The following is a description of a gene set: Human Gene Set: GSE22432_MULTIPOTENT_VS_COMMON_DC_PROGENITOR_UNTREATED_DN species: Homo sapiens Genes down-regulated in amplified multipotent progenitors versus cultured untreated common dendritic cell progenitors. from publication Felker P, Seré K, Lin Q, Becker C, Hristov M, Hieronymus T, Zenke M (PMID 20881193) Dendritic cells (DCs) in lymphoid tissue comprise conventional DCs (cDCs) and plasmacytoid DCs (pDCs) that develop from common DC progenitors (CDPs). CDPs are Flt3+c-kitintM-CSFR+ and reside in bone marrow. Here we describe a two-step culture system that recapitulates DC development from c-kithiFlt3-/lo multipotent progenitors (MPPs) into CDPs and further into cDC and pDC subsets. MPPs and CDPs are amplified in vitro with Flt3 ligand, stem cell factor, hyper-IL-6 and insulin- like growth factor-1. The four-factor cocktail readily induces self-renewal of MPPs and their progression into CDPs and has no self-renewal activity on CDPs. The amplified CDPs respond to all known DC poietins and generate all lymphoid tissue DCs in vivo and in vitro. Additionally, in vitro CDPs recapitulate the cell surface marker and gene expression profile of in vivo CDPs and possess a DC-primed transcription profile. Transforming growth factor-β1 (TGF-β1) impacts on CDPs and directs their differentiation towards cDCs. Genome-wide gene expression profiling of TGF-β1-induced genes identified transcription factors, such as interferon regulatory factor-4 (IRF-4) and RelB, that are implicated as instructive factors for cDC subset specification. TGF-β1 also induced the transcription factor inhibitor of differentiation/DNA binding 2 (Id2) that suppresses pDC development. Thus, TGF-β1 directs CDP differentiation into cDC by inducing both cDC instructive factors and pDC inhibitory factors., and this is the list of marker genes: IL1R2, EXOC2, DDX51 (DEAD-box helicase 51), SLC19A2, POLR1E, TRIM37, PWP2, ALG8, PIGM, RIPK2, NDUFB4, BZW2, ATXN7L3, SEH1L, SNHG7, RUVBL2, BFAR, CDC16, C5orf15, SNRPB2, ORC2, JAGN1, POLR3G, POP1, INTS15, RCE1, CTSZ, FPGS, JADE3, HIRIP3, PEX11A, TNIP2, PIAS2, MRPL55, DOHH, GFER, CEP83, IDI1, MYBBP1A, ILDR1, RWDD4, MTFR2, DDX49, MCRIP2, TMEM170B, ATP5MC1, IL10, BAG5, OTUD4, KRAS, UTP11, HIVEP3, HNRNPDL, PURA, ISYNA1, ACER3, DDX10, RASGEF1B, PFDN4, RSL1D1, ERH, TUSC2, RIOX2, MSMO1, BACH1, MNT, TMEM177, FXYD5, FDFT1 (NCBI Gene Id 2222), TSEN54, NOP16, CAMSAP1, TELO2, LETM1, CXCL10, BOP1, PIN1, PRPF19, SUB1, NIP7, GUK1, RBM15B (RNA binding motif protein 15B), RNF126, PRMT7, MAGOH, MRGBP, RRN3, KDSR, CALU, REV1, MFSD2B, METAP2, YES1 (NCBI Gene Id 7525), PDIK1L, USP22, AZIN1, TRAF4 (NCBI Gene Id 9618), FAM162A, UBXN2A, SHMT2, PNPO, FAM50A, PRKX, DUSP4, PCNA, UTP15, LSM6, SRSF3, CHD4, CTNNA1, PIGY (phosphatidylinositol glycan anchor biosynthesis class Y), NOC4L, MAP2K3, STX11, POGLUT1, C7orf25, KICS2, OVCA2, PPAT, CBFB, TLCD1, PHB2, DNAJA2, DNMT3B, INO80, APRT, FBL, RBM19, AARS1, MRPL46, EEA1, NOL11, OSGIN2, INTS14, RSL24D1, BTBD19, DNAJC16, UBE2G1 (ubiquitin conjugating enzyme E2 G1), MARCKSL1 (MARCKS like 1), ZC3H15, CDV3, EIF4E, HMGB3, HYCC1, CC2D1B, EIF2B5, C19orf48P, DDX56, CTU1, HARS1, TPD52L2, PPFIA1, NAA20, SMCR8, DPM2, CMTR2, MRPL15, TMBIM1, ATP13A1, RTN4RL1, NSMCE2, AFG3L2, GSTT2, GPN1, ABHD11, TSR1, ZZZ3, RBIS, GEMIN5, ATL3, MORF4L2 (mortality factor 4 like 2), MYB, CCT4, CHAC2, NFX1, ZNF106, FNBP1, TBL3, TFE3, DARS1, CINP, C19orf25, SF3A3, CENPC, PSMG2, PGAM5, IPPK, SLC25A6, ECE2, NUP107, PTCD3, PTGES2, NUDC, GLRX5, CSTF1, DBF4, UTP25, PRDM1, PTDSS1, DPH2